The following is a description of a gene set: studied in species Homo sapiens Reactome Pathway: Regulation of GBP-mediated host defense part of: GBP-mediated host defense Guanylate-binding protein 1 (GBP1) activity is tightly regulated to balance antimicrobial defense and prevent excessive inflammation. Caspase-1 (CASP1) cleaves GBP1 at aspartate 192 (D192), producing inactive fragments that lose the ability to target intracellular Salmonella Typhimurium, recruit caspase-4 (CASP4), or induce pyroptosis. This cleavage acts as a feedback mechanism to limit pyroptotic cell death during bacterial infection but does not occur during Toxoplasma gondii infection, indicating pathogen-specific regulation (Naschberger E et al., 2017; Fisch D et al., 2020). The kinase PIM1 phosphorylates GBP1 at Ser156 and Thr590, with Ser156 phosphorylation promoting binding to 14-3-3σ (SFN), which sequesters GBP1 in the cytosol and suppresses its membrane-associated antimicrobial activity (Fisch D et al., 2023). GTP binding disrupts the PIM1:GBP1 complex through an allosteric mechanism, highlighting how GBP1 integrates nucleotide- and phosphorylation-dependent control to fine-tune host defense (Persico M et al., 2015; De Donato M et al., 2012; Andreoli M et al., 2014)., and this is the list of marker genes: SFN, CASP1, GBP1, PIM1